Given this list of marker genes CORO1C, RET, SHH, EFNB1, ISL1, SEMA6C, SEMA3G, TBX1, SOX10, CFL1, SEMA6A, OVOL2, FN1, GBX2, CDC42, RADIL, SEMA3A, SEMA5B, ZEB2, SEMA3D, PHOX2B, SEMA4G, HIF1A, HAND2, SEMA6D, ERBB4, PITX2, SEMA4A, EDN3, SEMA6B, SEMA3E, ENG, SEMA4B, SEMA3C, EDN1, KITLG, SEMA4D, TPBG, SOX8, SEMA3F, NRP1, CDH2 (cadherin 2), NRP2, SEMA4F, SEMA5A, SEMA7A, EDNRA, FGF19, EDNRB, SEMA4C (NCBI Gene Id 54910), TWIST1, BMP4, SMO, LAMA5, SEMA3B, GDNF, HTR2B, FOLR1, ACVR1, NRTN, BMP7, PHACTR4, here is a description of the gene set: The orderly movement of a mesenchymal cell from one site to another, often during the development of a multicellular organism. Human Gene Set: GOBP_MESENCHYMAL_CELL_MIGRATION studied in species Homo sapiens